The following is a description of a gene set: Elevated circulating short-chain acylcarnitine concentration Human Gene Set: HP_ELEVATED_CIRCULATING_SHORT_CHAIN_ACYLCARNITINE_CONCENTRATION Concentration of short-chain acylcarnitine in the blood circulation above the upper limit of normal. Acylcarnitines are classified according to the number of carbon atoms in the acyl-chain. Short chain acylcarnitines have between two and five carbon atoms in the acyl-chain (C2-C5), species: Homo sapiens, and this is the list of marker genes: MMAB, IVD, LMBRD1, ABCD4, GCDH (glutaryl-CoA dehydrogenase), ETHE1